Given this list of marker genes KLHL25, BRCA1, APOC3, INSIG2, APOC1 (NCBI Gene Id 341), ACADL, MIR766, ERLIN1 (NCBI Gene Id 10613), DCAF5, MIR33A, SIRT1, INSIG1, MIR342, ACADVL, UBR4, MIR548P, ANGPTL4, MIR204, ERLIN2, CYP7A1, MIR132, MIR30C1, PIBF1, WDTC1, TRIB3, CEACAM1, MIR185, here is a description of the gene set: studied in species Homo sapiens Any process that stops, prevents, or reduces the frequency, rate or extent of the chemical reactions and pathways resulting in the formation of fatty acids. Human Gene Set: GOBP_NEGATIVE_REGULATION_OF_FATTY_ACID_BIOSYNTHETIC_PROCESS